Given this list of marker genes MAP2K5, MAPK7, here is a description of the gene set: Reactome Pathway: Signalling to ERK5 studied in species Homo sapiens part of: Signaling by NTRK1 (TRKA) The location of neurotrophin stimulation appears to determine the nature of the transcriptional response through differential uses of individual MAP kinases. The ERK5 pathway has a unique function in retrograde signalling; in contrast, ERK1/2, which mediate nuclear responses following direct cell body stimulation, does not transmit a retrograde signal. Following neurotrophin stimulation of distal axons, phosphorylated TRK receptors are endocytosed and transported to the cell bodies, where MEK5 phosphorylates ERK5, leading to ERK5 nuclear translocation, phosphorylation of transcription factors, and neuronal survival. In contrast, neurotrophin stimulation of the cell bodies causes concurrent activation and nuclear transport of ERK1/2 as well as ERK5. Several distinctive features of the ERK5 pathway might be important for retrograde signalling. The ERK5 cascade does not depend on activation of the G-protein RAS. Instead, this pathway may use other G-proteins such as RAP that are associated with vesicles, or may not require any G-protein intermediate. Another distinctive feature is that the MEK5 isoform, which is expressed in the nervous system, exhibits a punctate staining pattern, suggesting a vesicular localization. ERK5 itself significantly differs from ERK1/2, and its substrate specificity also differs from ERK1/2. For instance, ERK5 directly activates transcription factors, including MEF2, that are not phosphorylated by ERK1/2. Conversely, ERK1/2, but not ERK5, activate transcription factors such as ELK1 and MITF.